Given this list of marker genes RAB27B, AP4B1, AFTPH, RASSF9, AP1S1, SLC18A3, CLTCL1, FURIN, TGOLN2, SORT1, AP1M1 (adaptor related protein complex 1 subunit mu 1), ATP7A, AP1G1, CLRN1, TMED9, AP1G2, AP1B1, CLTC, RAB8A, NCALD, RAB13, AP1S3, RAB14, SYNRG, CLBA1, TMED10, RAB12, RAB8B, CLTA, GOPC, SPG21, CLTB, STEAP2, NRGN, AP2A1, SLC2A4, AP1M2, AP1S2, IGF2R, here is a description of the gene set: A vesicle that mediates transport between the trans-Golgi network and other parts of the cell. Human Gene Set: GOCC_TRANS_GOLGI_NETWORK_TRANSPORT_VESICLE studied in species Homo sapiens